The following is a description of a gene set: Mouse Gene Set: GOBP_DIADENOSINE_POLYPHOSPHATE_CATABOLIC_PROCESS studied in species Mus musculus The chemical reactions and pathways resulting in the breakdown of diadenosine polyphosphate, a derivative of the nucleoside adenosine with phosphate groups attached., and this is the list of marker genes: Fhit, Nudt4, Nudt11 (NCBI Gene Id 58242), Nudt3, Nudt10